The following is a description of a gene set: species: Mus musculus Mouse Gene Set: GOBP_POSITIVE_REGULATION_OF_RECEPTOR_MEDIATED_ENDOCYTOSIS Any process that activates or increases the frequency, rate or extent of receptor mediated endocytosis, the uptake of external materials by cells, utilizing receptors to ensure specificity of transport., and this is the list of marker genes: Plcg2, Trf, H1f1, Ntf3, Nsf, Sele, Ap2m1, Pcsk9, Ldlrap1, Plk2, Serpine1, App, Cd63, B2m, Syk, Il4, Ptpn5, Wasl, Hnrnpk, Drd2, Apela, Hamp2, Sfrp4, Hip1r, Hip1 (huntingtin interacting protein 1), Pld2, Arrb2, Rab21, Dgkd, Pick1 (NCBI Gene Id 18693), Vtn, Dtnbp1, Sgip1, Cbl, Anxa2, Ppt1, Fmr1, Atad1, Angpt1, Clu, Apln, Ap2a1, Synj1, Ccr7, Hfe, C3, Magi2, Hamp, Bicd1, Wnt3a, Dnm2, Synj2bp, Ahi1, Arrb1, Vegfa, Ccl21a, Tbc1d5, Egf, Dab2 (disabled 2, mitogen-responsive phosphoprotein), Pard3, Aplnr, Ccl19, Grem1, Insr, Kif3a